Given this list of marker genes SOSTDC1, ACVR1, ACVRL1, ACVR2A, BMPR1A, BMPR2, BMPR1B, HJV, here is a description of the gene set: species: Homo sapiens Combining with a member of the bone morphogenetic protein (BMP) family, and transmitting a signal across the plasma membrane to initiate a change in cell activity. Human Gene Set: GOMF_BMP_RECEPTOR_ACTIVITY